The following is a description of a gene set: studied in species Homo sapiens Human Gene Set: MIR1272 from publication Chen Y, Wang X (PMID 31504780) Genes predicted to be targets of miRBase v22 microRNA hsa-miR-1272 in miRDB v6.0 with MirTarget v4 prediction scores > 80 (high confidence targets)., and this is the list of marker genes: HYAL3, HTN1, LYRM7, MED6, TMEM167A, GRM1, MCOLN2, FAM83C, SKIC3, NOVA1, GJA1, CISD1, VWA2, CXCL6, PGR, TCTN3, FNIP1, WNT16, MECP2, IGF2BP3, USP33, EIF4E3, CYP27B1, MS4A4A, FLT1, RSF1, CCNT1, MBNL3, CIBAR1, GOLPH3L, USP38, C5orf24, DACH1, CAPZA2, SHISA7, PLA2G12A, PDK3, TRAM1, PTCHD4, PDE1C, RIF1, UNC45B, DMP1, SUPT3H, C4BPA, EIF2AK4, ZEB1, NCKAP1L, TCERG1L, VGLL3, CBLN4, LRP8, ADAMDEC1, SLC12A6, OLFM3, TRAF5, AKAP6, SYNPR, CNTN1, PLA2G4E, LETM1, THUMPD3, PCDHB16, POPDC3, BCAS2, DCAF6, DSG2, C11orf71, GSG1L, GCNT1, MAP3K20, DNA2, LRTOMT, GATA3, MEIG1, RANBP3, ZNF28, ADAM9, PDE3B, IGFBP1, KIAA1191, MDM1, SLC35D1, BCAP29, UGT2B4, GRB14